The following is a description of a gene set: Mouse Gene Set: GOMF_GAP_JUNCTION_CHANNEL_ACTIVITY species: Mus musculus A wide pore channel activity that enables a direct cytoplasmic connection from one cell to an adjacent cell. The gap junction can pass large solutes as well as electrical signals between cells. Gap junctions consist of two gap junction hemi-channels, or connexons, one contributed by each membrane through which the gap junction passes., and this is the list of marker genes: Gjc3, Panx3, Gjb2, Gjd3, Gja10, Gja1, Gja6, Gjb1, Gja3, Gje1, Gjc2, Gjb6, Gjb5, Gja8, Gjd4 (NCBI Gene Id 353078, gap junction protein, delta 4), Gja5, Gjd2, Gjc1, Panx1, Gjb3, Gja4, Gjb4, Panx2